Given this list of marker genes NOTCH1, MIR92A1, MIR9-1, ANTXR1, CST3, TGFB1, MIR98, ADTRP, MIR29B1, TGFBR3, TIMP3, RECK, TNFRSF1A, FAP, PPARG, TNFRSF1B, MIR27B, MIR19B1, MIR19A, EMILIN1, MIR18A, CHADL, MIR483, MIR145, MIR24-1, MIR29C, DPP4, here is a description of the gene set: Any process that stops, prevents or reduces the frequency, rate or extent of extracellular matrix organization. Human Gene Set: GOBP_NEGATIVE_REGULATION_OF_EXTRACELLULAR_MATRIX_ORGANIZATION species: Homo sapiens